Given this list of marker genes POR, GNAS, GDF5, MUSK, TNFRSF11B (NCBI Gene Id 4982), PTDSS1, ENPP1 (ectonucleotide pyrophosphatase/phosphodiesterase 1), WNT7A, FGFR1, PERP, MBTPS2, ZMPSTE24, TRPV3, GNAI3, NOG, FGFR2, ANKH, ADGRG6, MMP2, here is a description of the gene set: species: Homo sapiens Ankylosis A reduction of joint mobility resulting from changes involving the articular surfaces. Human Gene Set: HP_ANKYLOSIS